The following is a description of a gene set: Potential targets of MIR302A. species: Homo sapiens Human Gene Set: CARD_MIR302A_TARGETS from publication Card DA, Hebbar PB, Li L, Trotter KW, Komatsu Y, Mishina Y, Archer TK (PMID 18710938) Oct4 and Sox2 are transcription factors required for pluripotency during early embryogenesis and for the maintenance of embryonic stem cell (ESC) identity. Functional mechanisms contributing to pluripotency are expected to be associated with genes transcriptionally activated by these factors. Here, we show that Oct4 and Sox2 bind to a conserved promoter region of miR-302, a cluster of eight microRNAs expressed specifically in ESCs and pluripotent cells. The expression of miR-302a is dependent on Oct4/Sox2 in human ESCs (hESCs), and miR-302a is expressed at the same developmental stages and in the same tissues as Oct4 during embryogenesis. miR-302a is predicted to target many cell cycle regulators, and the expression of miR-302a in primary and transformed cell lines promotes an increase in S-phase and a decrease in G(1)-phase cells, reminiscent of an ESC-like cell cycle profile. Correspondingly, the inhibition of miR-302 causes hESCs to accumulate in G(1) phase. Moreover, we show that miR-302a represses the productive translation of an important G(1) regulator, cyclin D1, in hESCs. The transcriptional activation of miR-302 and the translational repression of its targets, such as cyclin D1, may provide a link between Oct4/Sox2 and cell cycle regulation in pluripotent cells., and this is the list of marker genes: IKZF2, RB1, PPP6C, TARDBP, CDC37L1, KAT6A, STAT3, CNOT7, NEUROG2, CLOCK, FOXJ3, TSHZ3, ASAP1 (ArfGAP with SH3 domain, ankyrin repeat and PH domain 1), MAP1B, MYT1, E2F1, SMAD7, ARID4B, RBBP6, CCND1, CCND2, FOXG1, E2F5, HLF, SLITRK3, RB1CC1, MNT, DDX5, VLDLR, CDK2, ZHX2, WNT9B (NCBI Gene Id 7484), PHTF2, RBL2, ZFHX4, DNMT1, RARB, ZNF367, TGFBR2, SASH1, TWIST1, PFN2, FBXO21, KLF9, KPNA2, SOX11 (NCBI Gene Id 6664), EFNB3, RAB5C, WEE1, RNF6, MBD2, RIC8B, EPHA4, LIMK1, SRSF2, STC1, RORB, ZFPM2, RBBP7, VEGFA, ZDHHC9, CCNG2, ARID4A, NR2F2, YES1, EIF4G2, JAZF1, NEUROD1, ZNF385A, JUNB, CDK6, NANOS1 (nanos C2HC-type zinc finger 1), RBBP4, DLL1, EPC2, TNFSF11, FOXJ2